The following is a description of a gene set: Catalysis of the cleavage of a phosphorus-oxygen bond by other means than by hydrolysis or oxidation, or conversely adding a group to a double bond. Human Gene Set: GOMF_PHOSPHORUS_OXYGEN_LYASE_ACTIVITY studied in species Homo sapiens, and this is the list of marker genes: BST1 (bone marrow stromal cell antigen 1), GNAI1, RAF1, ADCY2, TKFC, GUCA2B, ADCY3, NPR1, GUCY1B1, GUCA1ANB-GUCA1A, GNAL, RCVRN, ADCY9, GUCA1A, GUCY1A2, NCS1, ADCY6 (NCBI Gene Id 23320), GNAZ, GRM7, GUCA1B (guanylate cyclase activator 1B), MOCS1, ADCY5, RNASET2, ADGRV1, CALM1, CALM2, GUCA1C, GNAO1 (NCBI Gene Id 2775), GUCY2D, CALM3, ADCY4, GUCY1A1, GNAS, GUCY2F, ADCY10, GUCY2C, ADCY8, NPR2, CD38, GUCA2A, RGS2, NHERF4, ADCY7, ADCY1